The following is a description of a gene set: This event has been computationally inferred from an event that has been demonstrated in another species.<p>The inference is based on the homology mapping from PANTHER. Briefly, reactions for which all involved PhysicalEntities (in input, output and catalyst) have a mapped orthologue/paralogue (for complexes at least 75% of components must have a mapping) are inferred to the other species. electronically inferred by orthology from the curated human pathway species: Mus musculus Reactome Pathway: Cellular responses to stimuli, and this is the list of marker genes: Fnip1, Nup54, Sqstm1, Cox8a, Ppp2r2a, H2bc1, Capns2, Fzr1, Ube2s, Nox4, Flcn, Ppp2r1b (protein phosphatase 2, regulatory subunit A, beta), Nup155, Mapk14, Ep300, Hsbp1, Sirt1, Prdx1, Apob, Cox5a, Lmnb1, Prkar1b, Psmb4, Nudt2 (NCBI Gene Id 66401), H2ac15, Gng10, Prkar2b, Sod2, Rps27a, Fnip2, Oma1, Erf, H2az2, Psmc3, Fos, H2bc8, Akt1s1, Mre11a (MRE11A homolog A, double strand break repair nuclease), Aaas, Gng3, Blvrb, Sesn2, H2bc13, H4c6, H4c2, Kdm6b, Rraga, Tuba3b (NCBI Gene Id 22147), Eef1a1, Adm, Tuba1a, Hspa12a, Anapc15, Xpo1, Eif2s3x, Gng11, Nup85 (NCBI Gene Id 445007), Prkaca, Gng4, Map2k4, Med1, Eif2ak1, Lamtor5, Eif2ak3, Nup42, Nup133, Mapkapk5, Psma1, Psma5, Atp6v0d1, Higd1c, Hspa1l, H2bc15, Wdr59, H2bc22, Rheb, Hif1a, Nfkbia, Prdx3, Vcp, Psmd7, H4c3, H4c12, Phb2, Tubb2b (tubulin, beta 2B class IIB), H2ac4 (NCBI Gene Id 319172), H2bc9 (H2B clustered histone 9), H4c14, Hdac3, Ncf2, Ube2c, Ar, H2ac13 (H2A clustered histone 13), Gpx3, Gpx6, Cox6c, Gstp1, Ikbkb, Psma4, Terf1, Atp6v0c, Ehmt1, Gngt1, Rbbp7, Gpx2, Ncf1, Kat5, Tubb4b, Stoml2, H4c18, Ccna1, Cox6a1, Bag3, Tlr4, Atp6v1f, H2ac23, Cox7c, Tubal3, Gngt2, Psmd1, Gpx7, Rpa1, Ep400, Txn1, Cdc26, Mapk8, Ptk2, Psmc4, Tuba4a, Mt2, Nr3c1, Vhl, Nfkb1, Cryab, Atp6v1e2, Actr1a, Hspa2, H4c11, Tuba8, Bmt2, Cox4i2, Nbn, Terf2, Hspb8, Actr10, Ubb, Ptpn1, Pgrmc2, Gpx8, Sod3, Rragc, H2ac6, Hikeshi, Psmc5, Yap1, Acd, Alb, Dctn1, H2bc3, Ncor2, Camk2b, H2ac19, Psma6, Bag4, Crebrf, Cdkn2b, Dctn6, Trp53, Rela, Psmd6, H2ac10, Psmb7, Anapc10, Hif3a (hypoxia inducible factor 3, alpha subunit), Rae1, Tuba1b, Prdx5, Anapc2, Cox7a1, H4c8, Cdkn1a, Map2k7, Tubb4a, Anapc7, Gng7, Nup205, Tuba1c, Map2k3, Bag1, Tubb6, Hmga1, Ets2, H2ac7, Gnb3, Txnrd1, Mapk9, Map1lc3b, Psmd13, Ccs, Fkbp4, Atp6v1a, Cox7a2l, Szt2, P2ry2, Helz2, H2bc11, Cox8c, Hspa14, H2ac8, Mul1, Dnajb1, Ly96, Wdr24, Mink1, Gnb5 (NCBI Gene Id 14697), Castor2, Psmd12, Nup58, Ccne1, Anxa2, H2ac1, Apoa1, Psmc2, Cdc23, Hsph1, Ero1a, Kics2, Ccne2, Cdk4, Nup210, Atp6v0e2, Hbb-bt, Jun, H1f5, H2ax, Map2k6, Dnajb6, Ndc1, H1f3, Atp6v1d, Ube2e1, Dync1li2, Psma2, Hspa12b, Rictor, H4c4, H2ac20 (H2A clustered histone 20), H2bc12, Psmb5 (NCBI Gene Id 19173), Gng5, Tcirg1, H2bc7, Hsf1 (heat shock factor 1), Sin3a, Ndufa4, Nup93, Carm1, Psma7, Cycs, Prkacb, Atp6v1g2, Hmox2, Mapk7, Gpx1, Rb1, Cdkn1b, Calm1, H4c9, Cox6a2, Gng8, Psmc6, Mafk, Ywhae, Gnb2, H2ac11, Psmc1, Mt3, Lamtor4, Atp6v1c2, H2ac24, Ncoa1 (nuclear receptor coactivator 1), H4c17, Cul1, Atp6v1g3, Tbl1x, Lamtor2, H1f4 (H1.4 linker histone, cluster member), Rps19bp1, Txnrd2, St13, Ezh2, H4c1, Epas1, Psma3, Cyba, Lamtor1, Ufd1, Seh1l (NCBI Gene Id 72124), H1f1, Cox4i1, Mapk11, Atp6v0e, Dynll1 (dynein light chain LC8-type 1), Cited2, H2ac22, Rbbp4, Yme1l1, Mapk3, Psmb6, H2ac12, Pdpk1, H2bc27, Itga5, Ajuba, Esr1, P4hb, Ube2d1, Castor1